The following is a description of a gene set: Mouse Gene Set: GOBP_NEGATIVE_REGULATION_OF_ESTABLISHMENT_OF_PROTEIN_LOCALIZATION_TO_MITOCHONDRION Any process that stops, prevents or reduces the frequency, rate or extent of establishment of protein localization to mitochondrion. studied in species Mus musculus, and this is the list of marker genes: Siah3, Dnaja1, 4930550C14Rik, Lrrk2, Mapt, Nol3, Bag3, Bag4